Given this list of marker genes ZNF484, FERRY3, PNRC1, NKAIN2, DUSP16, MATN2, INSM1, TJP1, PGM3, KIR2DS4, GABRG3, OPCML, OLFM3, SCARA3, KIR2DL4, SMOC2, CALCRL, CHIC1, ABO, KCNV1, RGS22, PTPRT, OR11A1, ATF7 (activating transcription factor 7), ANO4, NSD2, EYS (NCBI Gene Id 8414), AR (androgen receptor), KCND2, SDHAF3, DCUN1D2 (NCBI Gene Id 56234, defective in cullin neddylation 1 domain containing 2), KCNN3, EPHA1, SLCO3A1, CLEC2D, SYNJ1, HMGXB4, CSMD1, PTBP3, RANBP17, PPP4R2, DCC, SSBP2, ESYT3, KLHL9, DIO2, GJC3, GPC5, FNDC3A, KIR3DL2, ABCC2, AGO3, UGT8, BTAF1, COG6, CDK8, BTN2A1, TFAP2B, ZFP36L1, KIN, GCLC, MCTP2, DNMT3A, KIR2DL3 (NCBI Gene Id 51344), MOB3B, KCNH7, SCUBE3, IGF2R, KCNJ3, KLHL7, ABCC4, ANGPTL3, EIF4G3, RNF220, VPS13C, AMMECR1, PAPSS2, FLI1, TTC23L, ANXA7, ZNF268, MKLN1, FANCD2, BVES, AK9, FMR1, ALG13, SLC39A8, NRXN1, RXRG, ZDHHC15, FCGR3B (NCBI Gene Id 2215), OPA1, API5 (NCBI Gene Id 95494, apoptosis inhibitor 5), ACLY (NCBI Gene Id 47), YPEL5, PWWP3B, HOXC9, KANSL1L, ZNF280D, P2RY14, CA10, CCDC191, MADCAM1, PCSK2 (NCBI Gene Id 5126), RNF11, PASK, OXNAD1, CRPPA, NTRK3, KIR2DL1, NLRP14, UTS2B, ATRN, ARHGEF33, TAF9B, ROCK2 (NCBI Gene Id 9475), FAM120C, VEGFA, FCGR3A, KIR3DL1, ANKUB1, MTREX, UBR3, BIVM, LRCH1 (leucine rich repeats and calponin homology domain containing 1), WDR64, PLA2G4A, RPAP2, CAMTA1, ABR, MYO1D, ADGRL2, CREBRF, SPOPL, HIVEP3, ZFX, CFAP418, TFEC, AZIN1, PIK3R1, SH3RF2, GLCCI1, APOOL, SLC16A14, CACNA1G, NEK7, DISC1, CPSF2, TSNAX, here is a description of the gene set: studied in species Homo sapiens Genes predicted to be targets of miRBase v22 microRNA hsa-miR-297 in miRDB v6.0 with MirTarget v4 prediction scores > 80 (high confidence targets). from publication Chen Y, Wang X (PMID 31504780) Human Gene Set: MIR297